The following is a description of a gene set: from publication Zhan F, Huang Y, Colla S, Stewart JP, Hanamura I, Gupta S, Epstein J, Yaccoby S, Sawyer J, Burington B, Anaissie E, Hollmig K, Pineda-Roman M, Tricot G, van Rhee F, Walker R, Zangari M, Crowley J, Barlogie B, Shaughnessy JD Jr (PMID 16728703) To better define the molecular basis of multiple myeloma (MM), we performed unsupervised hierarchic clustering of mRNA expression profiles in CD138-enriched plasma cells from 414 newly diagnosed patients who went on to receive high-dose therapy and tandem stem cell transplants. Seven disease subtypes were validated that were strongly influenced by known genetic lesions, such as c-MAF- and MAFB-, CCND1- and CCND3-, and MMSET-activating translocations and hyperdiploidy. Indicative of the deregulation of common pathways by gene orthologs, common gene signatures were observed in cases with c-MAF and MAFB activation and CCND1 and CCND3 activation, the latter consisting of 2 subgroups, one characterized by expression of the early B-cell markers CD20 and PAX5. A low incidence of focal bone disease distinguished one and increased expression of proliferation-associated genes of another novel subgroup. Comprising varying fractions of each of the other 6 subgroups, the proliferation subgroup dominated at relapse, suggesting that this signature is linked to disease progression. Proliferation and MMSET-spike groups were characterized by significant overexpression of genes mapping to chromosome 1q, and both exhibited a poor prognosis relative to the other groups. A subset of cases with a predominating myeloid gene expression signature, excluded from the profiling analyses, had more favorable baseline characteristics and superior prognosis to those lacking this signature. Top 50 down-regulated genes in cluster LB of multiple myeloma samples belonging to the low bone disease group. Human Gene Set: ZHAN_MULTIPLE_MYELOMA_LB_DN studied in species Homo sapiens, and this is the list of marker genes: RTP4, DDX60, AKNA, MX2, WIPF1, HIF1A, MAN1C1, PSMB10, BASP1, IFIT5, CASP4, STAT1, IFI6, IFI27, CCR2 (C-C motif chemokine receptor 2), LY6E, ZMIZ1, TACC1, SEPHS1 (selenophosphate synthetase 1), IRF1, ZC3H12C, H3C4, CKLF, USP18, STAT2, LYSMD2, TRAF5, DUSP6, LINC00869, PARP8, CASP4LP, TMEM255A, RSAD2, IFI35, GTPBP1, PTPRCAP, CAP1, ZNF818P, SMAD1, XAF1